The following is a description of a gene set: species: Homo sapiens Human Gene Set: MODULE_470 Genes in the cancer module 470., and this is the list of marker genes: PTGS2, PF4, PPBP, ADGRL4, STAR (NCBI Gene Id 6770), PRLR, PFKL, ADGRB3, ARHGAP22, IGFBP5, TMPRSS15, ADGRL2, ABCA2, VIPR1, MAOA, PTH1R